The following is a description of a gene set: from publication Chen Y, Wang X (PMID 31504780) Genes predicted to be targets of miRBase v22 microRNA hsa-miR-8071 in miRDB v6.0 with MirTarget v4 prediction scores > 80 (high confidence targets). Human Gene Set: MIR8071 species: Homo sapiens, and this is the list of marker genes: MRM3, NWD1, MTCL2, TRAK1, CABP7, FAM13B, SSB, ZNF709, TMEM253, HDAC2, PDK1, CCDC93, KCTD1, CXXC4, TRIM33, SNX6, MRTO4, PURA, DCAF8, BACE1, SYT7, NHS (NCBI Gene Id 907), SHISA7, SEMA3F, DENND2C, DCLK2, SYNPO2, RPS6KA4, TNS1, PPP1CC, GPX3, BAZ1B, ZSWIM5, PRDM11